The following is a description of a gene set: Human Gene Set: LEE_LIVER_CANCER_E2F1_UP Genetically modified mice have been extensively used for analyzing the molecular events that occur during tumor development. In many, if not all, cases, however, it is uncertain to what extent the mouse models reproduce features observed in the corresponding human conditions. This is due largely to lack of precise methods for direct and comprehensive comparison at the molecular level of the mouse and human tumors. Here we use global gene expression patterns of 68 hepatocellular carcinomas (HCCs) from seven different mouse models and 91 human HCCs from predefined subclasses to obtain direct comparison of the molecular features of mouse and human HCCs. Gene expression patterns in HCCs from Myc, E2f1 and Myc E2f1 transgenic mice were most similar to those of the better survival group of human HCCs, whereas the expression patterns in HCCs from Myc Tgfa transgenic mice and in diethylnitrosamine-induced mouse HCCs were most similar to those of the poorer survival group of human HCCs. Gene expression patterns in HCCs from Acox1(-/-) mice and in ciprofibrate-induced HCCs were least similar to those observed in human HCCs. We conclude that our approach can effectively identify appropriate mouse models to study human cancers. species: Homo sapiens Genes up-regulated in hepatocellular carcinoma (HCC) induced by overexpression of E2F1. from publication Lee JS, Chu IS, Mikaelyan A, Calvisi DF, Heo J, Reddy JK, Thorgeirsson SS (PMID 15565109), and this is the list of marker genes: RHOB, TAGLN2, COL5A2, PLSCR1, HOXC6, UAP1L1, COL1A1 (collagen type I alpha 1 chain), GGH, ACTG2, NUCB2, CD63, FMO3, PALMD, LCN2, TMEM176B, RPL36, CXCL10, SPARC, CTSS, LEPR, ANXA5, MFGE8, IFIT2, SPTAN1, TUBB2A, DYNLT1, CPE, MMP12, XDH, CSTB, CYP39A1, GSTM2, RAD51B, SHCBP1, PLAT, ETS2, CD74, ANXA2 (NCBI Gene Id 792), CXADR, USP18, TM4SF4, ANXA1, PPL, DEFB1, JCAD, KRT8, CTSE, LY6E, NT5E, GSTM1, CASP4, IGFBP1, IFI44, ACTG1, KRT23, SPINK1, FABP4, GPC3, LPL, MCL1, SPON2, BCL2A1, TFF3